Given this list of marker genes UBA7, PBXIP1, GALT, ASGR1, EPHB6, AMPD2, TOMM40, GLG1, EIF4G1, PTK2, SEMA4B, KRT34, SGCG, IL11RA, TSPAN5, OAZ2, PRKG1, ARHGAP21, NUP107-DT, FBXL16, HDAC9, PPARD, PLXNB2, CRLF3, ZNF512B, NT5C2, ZNF76, SPACA6, CDH16, LINC02366, DAP, FLT4, GCLC, ECI1, PRUNE1, CABIN1, MBNL1 (NCBI Gene Id 9850), DDX56, MESD, E2F5, ID1, KLF1, RANBP10, NDUFA7, RBM25, LGALS3BP, SWI5, LMLN, KIF18B, NEXN, CCNE1, GATA3, ARIH2, PDLIM1, MT1A, TAOK2, CDH1, BAG6, WSCD2, FCGBP, SH3RF2, RAD51B, NR6A1, USP13, FBXW8, LRP5, CTBP2, FAM174B (NCBI Gene Id 400451), MAPK15, SPATA3-AS1, FGFRL1, PAX8, BCL2L11, FMO2, ARMCX4, SETD5, SLC29A2, RPS6KA2 (NCBI Gene Id 6196), here is a description of the gene set: species: Homo sapiens from publication Fontaine JF, Mirebeau-Prunier D, Franc B, Triau S, Rodien P, Houlgatte R, Malthièry Y, Savagner F (PMID 17968324) Human Gene Set: FONTAINE_FOLLICULAR_THYROID_ADENOMA_UP Genes up-regulated in follicular thyroid adenoma (FTA) compared to other thyroid tumors. Conventional histology failed to classify part of non-medullary thyroid lesions as either benign or malignant. The group of tumours of uncertain malignancy (T-UM) concerns either atypical follicular adenomas or the recently called 'tumours of uncertain malignant potential'. To refine this classification we analysed microarray data from 93 follicular thyroid tumours: 10 T-UM, 3 follicular carcinomas, 13 papillary thyroid carcinomas and 67 follicular adenomas, compared to 73 control thyroid tissue samples. The diagnosis potential of 16 selected genes was validated by real-time quantitative RT-PCR on 6 additional T-UM. The gene expression profiles in several groups were examined with reference to the mutational status of the RET/PTC, BRAF and RAS genes. A pathological score (histological and immunohistochemical) was estimate for each of the T-UM involved in the study. The correlation between the T-UM gene profiles and the pathological score allowed a separation of the samples in two groups of benign or malignant tumours. Our analysis confirms the heterogeneity of T-UM and highlighted the molecular similarities between some cases and true carcinomas. We demonstrated the ability of few marker genes to serve as diagnosis tools and the need of a T-UM pathological scoring.